Given this list of marker genes Septin10, Fdft1, Pkp2, Flot1, Atp6v1c1, Tmem37, Vcl, Dock9, Ccng2, Rab3il1, Anxa6, Cavin2, Acadl, Lrrfip1, Fam107b, Cpeb2, Zfand6, Uba3, Nol7, Lpl, Fdps, Mtm1, Pygb, Hmgcs1, Nsdhl, Sowahc, Gyg1, Sqle, Msmo1, Strbp, here is a description of the gene set: species: Mus musculus During cellular differentiation and development, it is recognized that many complex molecular mechanisms as well as precise patterns of differentially expressed genes occur in directing precursor cells toward a given lineage. Using microarray-based technology, we examined gene expression across the course of 3T3-L1 adipocyte differentiation. Total cellular RNA was isolated at times 0, 2, 8, 16, 24, 48, and 96 h following treatment with either standard hormonal inducers of differentiation; insulin, dexamethasone, isobutylmethylxanthine (IDX), or IDX plus trichostatin A (TsA), a histone deacetylase inhibitor and potent adipogenic inhibitor. cRNA was synthesized from cellular RNA and hybridized to high density Affymetrix MG_U74Av2 microarray gene chips containing 12,488 cDNA/Expressed Sequence Tags (ESTs) probe sets. From the IDX-only treated cells, all probe sets that were either unchanged or differentially expressed less than 2-fold throughout differentiation with respect to time 0 preadipocytes were excluded from further analyses. This selection resulted in a net of 1686 transcripts, 859 were increased in expression, and 827 were decreased in expression at least 2-fold across differentiation. To focus in on genes that were more specific to differentiation, the same analysis was performed on IDX plus TsA-treated non-differentiating cells and all probe sets from the IDX-only group that exhibited similar expression profiles in the non-differentiating TsA-treated group were excluded leaving a total of 1016 transcripts that were regulated only under differentiating conditions. Six hundred and thirty-six of these transcripts were elevated at least 2-fold and 380 exhibited a decrease in expression relative to time 0 preadipocytes. This group of genes was further analyzed using hierarchical clustering and self-organizing maps and resulted in the identification of numerous genes not previously known to be regulated during adipocyte differentiation. Many of these genes may well represent novel adipogenic mediators and markers of adipogenesis. from publication Burton GR, Nagarajan R, Peterson CA, McGehee RE Jr (PMID 15033539) Mouse Gene Set: BURTON_ADIPOGENESIS_10 Strongly down-regulated at 8-48 h during differentiation of 3T3-L1 cells (fibroblast) into adipocytes.